Given this list of marker genes NUP133, NOA1, EPRS1, CNKSR3, ZMAT3, ZNF689, GPKOW, DOCK4, EFHC1, MAP3K11, DNAJC13, PRXL2A, CGGBP1, DSG1, RBM44, PREPL (NCBI Gene Id 9581), TXNDC15, INTS10, ITPRIPL2, SYT4, BCLAF3, CCSER1, IBSP, GPR25, ZNF653, SMARCAD1, STXBP5L, SVIP, SLC19A2, HSD17B7, TOP1, PICALM, ROCK1, IWS1, RNF34, CD47, SLC35G1, PTPN4, DGKE, PWWP3B, PRIM2, AGFG1, FASTKD3, TMEM44, UNCX, PPP1R3B, ANKH, HEPH, MLF1, FDFT1, ISOC1, TACC1, MARK3, NEDD1, RAPH1, EMB, TOGARAM1, LINGO2, TEX36, SLC25A24, KAT14, SHPRH, LINGO3, RBM27, SLC25A40, PLXNA2, DIDO1, FBXL3, PRKCI, CAPG, CNOT11, ABITRAM, PDCD6IP, KIAA0825, SETDB2, MMS19, CD80, RHOA, OPTN, BBX, OSBPL1A, BLTP1, TTBK2, POLR2B (NCBI Gene Id 7890), CHAF1B, MTMR12, C5orf24, GALNTL5, GNAI3, TBPL1, KLHDC9, ENPP6, GPAM, PPP4C, PSMD14, RPS4X, MOAP1, BEX1, ATP7A, POLR1F, MAN1A1, ARL15, TAB3, TLE4, ANKRD44, BTRC, GPSM2, LRMDA, AP1G1, ARFGAP3, ZNF667, RAB1A, CCDC14, FEM1B, RNPEP, CCL11, NIN, BCKDHB, NSD2, RANBP17, RNF182, KLF6, POGZ, FXR1, TLK1, TRAP1, GTF3C5, CCDC91, FAM13B, CNOT6, CSNK1A1, ZZZ3 (NCBI Gene Id 26009), TNPO1, NAPEPLD, CEP57L1, KLF10, PPP1R2P1, POTEH, GALNT3, AGPS, CDK17, GZMH, CSN3, WNT9A, STYX (serine/threonine/tyrosine interacting protein), DLG1, RBPJ, SNX24, FAM151B, MAK16, DET1, KCTD10, SERPINA7, ZNF35, TADA1, CRLS1, MMS22L, NCOA1, NETO2, ZNF563, EEF1E1, SMIM15, CTDSPL2, PHTF1, RANBP2, MBNL3, USP45, PARP16, SLC15A5, CASP8AP2, GLS2, PROCA1, PREP, OTUB1, FN3KRP, ABCC10, CENPE, UBE3D, IFT70A, FAM217B, MFSD14B, ZFX, BBS7, RALGAPA1, CCDC106, NHLRC3, CCDC112, SLC45A4, GOT1, ONECUT2, DIAPH3, DEFB116, PHF20L1, HOOK1, RABGGTB, TADA2A, ABL2, EFCAB14, here is a description of the gene set: Bcl6 germline deletion causes a prominent inflammatory disease, owing to over-expression of Th2 cytokines, and affects the properties of B cells prior to immunization. Therefore we established the B cell-specific Bcl6 deletion mice and analyze the gene expression of naive B cells under physiological conditions. Genes down-regulated in marginal zone B lymphocytes: wildtype versus BCL6 knockout. Human Gene Set: GSE28737_WT_VS_BCL6_KO_MARGINAL_ZONE_BCELL_DN from publication Kaji T, Ishige A, Hikida M, Taka J, Hijikata A, Kubo M, Nagashima T, Takahashi Y, Kurosaki T, Okada M, Ohara O, Rajewsky K, Takemori T (PMID 23027924) studied in species Homo sapiens